The following is a description of a gene set: Genes down-regulated in acute myeloid leukemia (AML) samples with constitutively activated FLT3 or with activating point mutations within NRAS. Human Gene Set: NEBEN_AML_WITH_FLT3_OR_NRAS_DN In acute myeloid leukemia (AML), constitutive activation of the FLT3 receptor tyrosine kinase, either by internal tandem duplications (FLT3-ITD) of the juxtamembrane region or by point mutations in the second tyrosine kinase domain (FLT3-TKD), as well as point mutations of the NRAS gene (NRAS-PM) are among the most frequent somatic gene mutations. To elucidate whether these mutations cause aberrant signal transduction in AML, we used gene expression profiling in a series of 110 newly diagnosed AML patients with normal karyotype. The different algorithms used for data analysis revealed highly concordant sets of genes, indicating that the identified gene signatures are specific for each analysed subgroup. Whereas samples with FLT3-ITD and FLT3-TKD could be separated with up to 100% accuracy, this did not apply for NRAS-PM and wild-type samples, suggesting that only FLT3-ITD and FLT3-TKD are associated with an apparent signature in AML. The set of discriminating genes included several known genes, which are involved in cell cycle control (CDC14A, WEE1), gene transcription (HOXB5, FOXA1), and signal transduction (SMG1). In conclusion, we showed that unique gene expression patterns can be correlated with FLT3-ITD and FLT3-TKD. This might lead to the identification of further pathogenetic relevant candidate genes particularly in AML with normal karyotype. species: Homo sapiens from publication Neben K, Schnittger S, Brors B, Tews B, Kokocinski F, Haferlach T, Müller J, Hahn M, Hiddemann W, Eils R, Lichter P, Schoch C (PMID 15674343), and this is the list of marker genes: CYP2J2, HSPA5, LDHB, WEE1, RPS3 (NCBI Gene Id 6188), CCT8, SERPINH1, PKMYT1, RPL28, CDC14A, RAC2, KIF23